Given this list of marker genes TAF1, GTF2E2, ESR1, HNRNPU, GTF2A2, GTF2A1, RUVBL2, ERCC4, TAF1B, NOP58, CAND1, ZBTB43, NR3C2, BRF2, NR3C1, YEATS2, DRAP1, BRF1, IGHMBP2, BTAF1, TAF1L, THAP7, GTF2B, PSMC5, FOXF2, MED1, JUN, POLR1E, TBP, HHEX, CTDP1, TAF12, ZNHIT6 (zinc finger HIT-type containing 6), GTF2F1, AR, TP53, BDP1, RUVBL1, DR1, BCL10, TAF7, ERCC1, MTOR, EDF1, HSF1 (NCBI Gene Id 642255), TAF13, FBL, AHR, TAF11, RELA, TCF4, THRA, CAND2, ATF4, here is a description of the gene set: species: Homo sapiens Binding to a general transcription initiation factor, a protein that contributes to transcription start site selection and transcription initiation. Human Gene Set: GOMF_GENERAL_TRANSCRIPTION_INITIATION_FACTOR_BINDING